Given this list of marker genes ABCB1, LCT (NCBI Gene Id 3938), SLC7A5, ABCG2, SLC38A1 (solute carrier family 38 member 1), ABCC4, here is a description of the gene set: The leaflet the apical region of the plasma membrane that faces away from the cytoplasm and any proteins embedded or anchored in it or attached to its surface. Human Gene Set: GOCC_EXTERNAL_SIDE_OF_APICAL_PLASMA_MEMBRANE species: Homo sapiens